The following is a description of a gene set: species: Mus musculus Mouse Gene Set: GOBP_REGULATION_OF_MAP_KINASE_ACTIVITY Any process that modulates the frequency, rate or extent of MAP kinase activity., and this is the list of marker genes: Erbb2 (NCBI Gene Id 13866), Edn1, Smpd1, Nf1, P2rx7, Traf2, Thbs1, Gstp-ps, Ccl19, Sfrp2, Cd24a, Tnf, Cdk12, Map3k13, Tnfsf11, Map2k6, Pdgfb, Bmp2, Htr2b, Taok3, Dnaja1, Tnfrsf11a, Sfrp1, Lrrk2, Fzd8, Mapk8ip1, Pik3r6, Fzd4, Dab2ip, Dusp7, Map3k5, Ager, Cdk5rap3, Fgfr1, Cav1, Rgs14, Map2k7, Nek10, Rgs2, Ptprc, Ptprj, Arhgef5, Fgd2, Trib3, Kitl, Ksr1, Spry2, Ptpn6, Tlr6, Tenm1, Inpp5k, Trib1, Map3k10, Nppa, Dtnbp1, Ceacam1, Rps3, Cd300a, Hipk3, Syk, Flt1, Aida, Nox4, Wnt5a, Kit, Spry1, Map2k4, Gstp1, Adipoq, Fem1a, Adra2a, Dvl2, Spry4, Ern1, Lime1, Fzd5, Pik3r5, Maged1, Pdgfa, Ptpn22, Egfr, Pak1, Nup62, Ntf3, Gab1, Pdcd4, Map3k12, Lyn, Sash1, Apoe, Vangl2, Traf6, Hras, Map3k4, Gstp2, Ajuba, Pik3cg, Cblc, Irak3, Cd40, Map3k1, Erp29, Fgf1, Mst1r, Psen1, Drd4, Cav3, Map3k11, Irak1, Fcer1a, Hyal2, Trib2, Gstp3, Pparg, Bcl10, Cripto, Pde5a, Epha4, Gpr39, Insr, Edn3, Dusp10, Dusp19, Tlr4, Fgf2, Tpd52l1, Rasgrp1, Dusp1, Map4k2, Il1b, Robo1, Fgd4, Ptpn1, Hgs, Ezh2, Adam9, Gba1 (glucosylceramidase beta 1), Agt (angiotensinogen), Axin1, Map3k7, Sfrp5, Mapk8ip3, Fgf18, Ern2, Ccr7, Pdcd10, Pdgfrb, Hmgcr, Il34, Prkcd, Tsg101 (NCBI Gene Id 22088), Uchl1, Tirap, Paqr3, Ntrk3, Magi3, Zeb2, Stk38